The following is a description of a gene set: Human Gene Set: HP_ANAL_FISSURE A small tear in the thin, moist tissue (mucosa) that lines the anus. It appears as a crack or slit in the mucous membrane of the anus. Anal fissure studied in species Homo sapiens, and this is the list of marker genes: COL7A1, EGFR, CYBC1, ADAM17, MMP1